The following is a description of a gene set: The specific behavior of an organism relating to the intake of food, any substance (usually solid) that can be metabolized by an organism to give energy and build tissue. species: Homo sapiens Human Gene Set: GOBP_EATING_BEHAVIOR, and this is the list of marker genes: BSX, BBIP1, NMU, OXT, LEP, ADRB3, TACR1, TTC21B, OPRK1, RMI1, GHSR, C1QTNF4, MC4R, GFRAL, COL6A1, CNTN2, CCK, NAPEPLD, TH, TRH, CPT1A (carnitine palmitoyltransferase 1A), IAPP, GDF15, AGRP (NCBI Gene Id 181), TMEM18, NPSR1, P2RY1 (purinergic receptor P2Y1), UCHL1, GHRL, ADORA2A (adenosine A2a receptor), SLC24A4, HCRT, GUCA2B, NMUR2, NPY (NCBI Gene Id 4852), OPRD1, STAT3, ATP8A2, NPY5R, PRLH, BBS12